The following is a description of a gene set: species: Homo sapiens from publication Della Ragione F, Criniti V, Della Pietra V, Borriello A, Oliva A, Indaco S, Yamamoto T, Zappia V (PMID 11423116) Genes up-regulated in HT-29 cells (colon cancer) by the combination of trichostatin A (TSA) and sodium butyrate. Human Gene Set: DELLA_RESPONSE_TO_TSA_AND_BUTYRATE A wealth of evidence correlates the chemopreventive activity of a fiber-rich diet with the production of butyrate. In order to identify the genes transcriptionally modulated by the molecule, we analyzed the expression profile of butyrate-treated colon cancer cells by means of cDNA expression arrays. Moreover, the effect of trichostatin A, a specific histone deacetylase inhibitor, was studied. A superimposable group of genes out of 588 investigated is modulated by both butyrate and trichostatin A. Among them, a major target was tob-1, a gene involved in the control of cell cycle. tob-1 is also up-regulated by butyrate in a neuroblastoma-derived cell line, and its overexpression in the colon cells caused growth arrest. Our findings represent an extensive analysis of genes modulated by butyrate and identify completely new effectors of its biological activities., and this is the list of marker genes: CDKN1A, CDK10, HSPB1, RHOA, NET1 (neuroepithelial cell transforming 1), HSPA1A, PRDX1, CDC20, PRKCD, MAPRE1, NR4A1, RNH1, GATA2, GADD45A (NCBI Gene Id 1647), CXCR4, EPHB3, DDR1, POR, GSTT1, ICAM1, TOB1